Given this list of marker genes BCOR, PDK2, GRIN2A, FAM117A, PAX6, NOL8, APOA5, KAT14, VPS33A, EVC2, IGF2BP3 (NCBI Gene Id 10643), FAM76B, DOHH, LIN28A, AFF2, SFXN2, SAMD12 (NCBI Gene Id 50968), GPRC5C, NTHL1, GTF2A1, RXRB, HIRA, HLX, SRP72, AMD1, PLEKHA6, RRP8, RPS6KA5, PA2G4, TXNDC12, DHX35, MMP23B, FAF1, CEBPB, MARCHF8, RPS11, FHOD1, VGF, ZHX2, GNL1, NDUFAF4, APEX1 (apurinic/apyrimidinic endodeoxyribonuclease 1), BRDT, SPIN2A, FGF11, ZC3H10, CBX6, ALG1, RNF145, FARP1, RPL30, SLC25A51, ESR2, MPV17, MEA1, MCM8, CNPY2, ADNP (NCBI Gene Id 256440), SPNS1, KRTCAP2, CATSPERD, EIF3B, CAMK4, MON1A, GGN, SGTB, SRFBP1, UBXN6, SYBU, EME1, RASGRP2, SNN, CSDE1, METTL13, CEP63, DLX1, ABCA1, ARRDC3, TBL1Y, PLAGL1 (PLAG1 like zinc finger 1), C1orf43, THAP5, RHOBTB3, SPATA2L, LYPD1, PTCH1, PPM1A, ICAM5, CUL5, TOM1L2, ANKHD1-EIF4EBP3, CYP2D6, CACNA1D, ST6GAL1, CHD4, NEUROD6, HMGN2, TBL1X, NDUFA7, CD164, ARMCX6, CGN, FOXF2, PPP1R1B, ADSS2, GABARAP, NR5A1, ZFYVE26, RUNX1T1, BEX1, KCNN4, HOXB4, AK2, BHLHA15, SLC39A11, HYAL2, NRXN1, NUDC, TRIP10, RAB2A, YPEL5, AVP, ACY1, MNT, GPX1, POLH, HSPA4, DYM, B4GALT2, DIAPH1, POGK, FOXRED2, STAT3, NPM1, SUCLG2, ALDH18A1, HPCA, HMOX1, HOXA11, SLC25A33, RCL1, ASPHD1, CHRM1, SLC20A1, ARX, TTLL11, FEN1, SGO1, EWSR1, SERBP1, CACUL1, LMX1A, TUG1, SLC26A2, TCF4, KAT5 (NCBI Gene Id 10524), HEBP2, CAMK2D (calcium/calmodulin dependent protein kinase II delta), ADAMTS3, ARL3, TLL1, DUSP1, ZNF296, SMC3, ADK, DUSP4, ABCB6, TEX12, ARHGAP45, METAP1D (NCBI Gene Id 254042), TMEM132E-DT (TMEM132E divergent transcript), FOXO3, PDP2, NFX1, DOP1A, E2F8, PEPD, ABHD17B, GPC3, EEF1B2, SLC31A2, BEND4, E2F3, NTMT1, BCL9L, GLA, NET1, PRPS1, STX6, TCEAL8, TRMO, SORD, CCAR1, LMNB1, BHLHE40, P3H4, ADAM12, TCEAL1, TIAL1, TBC1D5, STMN1, KLF9, L1CAM, ARHGAP12, BATF3, XPO1, SLC39A7, LTBR, AIFM3, CBARP, MTHFD1, PSMB3, PTMA, TRAPPC8, NEFM, RNF43, LZTS2, RTN4RL2, SEPTIN3 (NCBI Gene Id 55964), LPCAT4, BARHL1, MTAP, HBP1, HSPE1, INO80, HERPUD1 (NCBI Gene Id 9709), EBNA1BP2, DDX4, PIAS4, PRR3, KCMF1, ZFP91, SLC7A5P1, SCFD2, RAB31, ERLIN1, CSK, AGMAT, ZBTB5, ANAPC13, SELENOS, PLCG2, ZCCHC7, ZNRF2, BFAR, CAMKK1, CLN3, KIAA0586, NR0B2, COMMD8, BCKDHA, NXPH1, TSSK3, B3GNT9, ALDOA, IGSF22, ABCC4, UBE2C, FBL, ATXN7L2, TEF, HRH3, TFAP4 (NCBI Gene Id 7023), EIF4G1, SMYD4, ESRP2, TIMM50, ATP6V1H, TRIM3, SHMT2, SUMF1, SEMA3F, CRMP1, HNRNPH3, SLC25A37, SLC7A3, RPS19, TFB2M (NCBI Gene Id 64216), ANXA6, SEMA7A, DERL3, ARMCX2, MGME1, PER1, CHRNA7, WDR77, REV1, SLC17A2, GIGYF2, LHX9 (LIM homeobox 9), PRKCE, MAP7, EMC1, CIPC, AKAP1, TMEM132E, LTV1, STT3B, BCAS3, CNNM1, FAXDC2, ILK, GLS2, ATF1, ZNF711, WEE1, PTGR3, CUTA, ACLY, FPGS, ARMC6, DCAF11, ODC1, PIK3IP1, PWP2, RBM19, PLAG1, ATP1B3, ZC2HC1C, ZBTB8OS, NR1D1, AMER1, RANBP1, ZNF503, HMGA1, ORAI2, XPO5, CEP57, SHOC1, LRP8, MIA2, TGIF2, SLC25A32, U2AF2, PLA2G6, TOP1, SGK1, SLC12A6, ILF3-DT, TMEM258, CLEC18C, NR4A3, ARMCX1, NAPA, SLC7A5, RORC, EIF4B, DNAAF1, WIPI1, DDX18, CPEB4, NKX2-2, DIABLO, TAFA4, SATB2, STC2, ACAN, GLYR1, CHST11, AGO2, DCUN1D4, MEPCE, CNPPD1, DLC1, KDM4C, MXD4, G6PC3, ATP6V1C1, HPS5, SLC33A1, PCDHA10, SPPL3, MPP3, PPP1R3B, KCNH4, WBP2, SSR1, NEUROD1, TSR3, RPS2, GRK6, RPUSD4, FMR1, DTNA, RRAGC, ACAP3, GYG1, KLF11, ATAD3A, DOLK, TSC2, TGFB2, ELK1 (NCBI Gene Id 2002), SEZ6L, MTUS1, CEBPA, SASH3, RETREG2, ENPP6, B3GALT6, IQCG, TNPO2, C15orf39, TNXB (tenascin XB), BMP7, NDUFS1, YBX3, TBX4, JADE2, KANSL1L, RFX4, ALX4 (NCBI Gene Id 64068), DRD1, EFNB1, ATF7IP, RMND1, CFAP57, SUPT16H, TSC1, ATG5, ATP5PB, HNRNPD, BATF2, MAFF, TSPAN4, ONECUT1, POLR1G, SLC43A1, SNCAIP, DSCAM, OGT, VPS13A, HNRNPH2, UBXN10, NOL4L, PNMA8A, UBR4, SPINK5, SDC1, IER5L, PABPC4, NAA25, DENND6A, MRTO4, UTP14A, AP3M1, POLR3C, HPCAL4, ZBTB49, RBBP7, SLC36A1, GPS1, FXR1 (NCBI Gene Id 8087), MFSD5, MEOX2, USP2, KDM6A, ELAVL3, SNRPA, NAT10, ANKRD12, RRAGB, UTP4, NOTCH1, COPZ1, NSD3, POP1, SNX2 (NCBI Gene Id 6643), ADISSP, SEC23IP, FABP3, CELF1, TAGLN2 (NCBI Gene Id 8407), PPAT, IQGAP2, ZNF574 (zinc finger protein 574), FGF14, EN1, ESYT1, AK3, YEATS2, PHC3, RUSC1, TIMM8A, MTCH2, FOXJ3, GNPTG, PABPC1, SCAMP3, HEXA, VLDLR, CLTC, KICS2, USP36, GTF2H1, RTN4R, ATIC, WDR17, GSK3B, PDIA4, SOCS2, ADAM10, COL25A1, CLCN2, NEURL2, TESK2, QTRT2, BDNF, TOM1, ZNF565, LONRF3, KLHDC3, PFDN2, ADCK1, KAT6A (lysine acetyltransferase 6A), AKAP12, ARPC5, ATXN3, PICALM, NPTN, SHMT1, KBTBD2, FCHSD2, REXO2, FOXD3, RPIA, MED28, BCL6, TET2, CEP95, MYO19, TMED10, SMAD2, ETV1 (ETS variant transcription factor 1), HOXC13, TOPORS, SLCO1C1, RAD50, PRDM4, PPP1R3C, EIF3J, RNF115, HSPD1, RBBP4, HOXA1, NUP153 (nucleoporin 153), POLR2H, MICAL2, KCTD15, SPG21, PKN1, PDPR, NOP56, POLR3D, UBR5, GJA1, TMEM108, EN2, CDKN2C, ACACA, THUMPD2, CTBP2, AATF, DNTTIP2, LAP3, ATP6V1A, SNCB, TGFB3, BCL7C, ANGPT2, HOOK2, EPB41, CBX5, INSM1, POLR2L, OBI1, CEP83, ZMYND12, VPS26A, DNAJB9, NRIP3, COPS7A, UBE2B, RNF44, CAMKK2, LDHA, GIT1, ACVR2B, RHEBL1, ABCA2, JADE1, STK31, EYA4, WDR46, HOXB7, ERCC6, VPS50, IRS4, POGLUT1 (protein O-glucosyltransferase 1), SLC4A11, EEF1E1, CCER1, IPO7, SLC38A2, SLC1A7, RSPRY1, UTP18, NUDT11, HSPA9, STMN4, RAD9A, AEN, GK, PSME3, REEP3, C9orf85, MAT2A, MTFP1, RABGAP1, TLE4, SYT6, SLCO5A1, PBRM1, VWA2, CAMKV, BOK, EPC1, BMP2, WASHC4, ADPRHL1, ZNHIT6, PAICS, TAC1, SYNRG, GNAS, SLC12A5, RBBP6, AVPI1, IGF2BP1, HSDL1, XRN2, CREBRF, PRR7, UBE3D, MACROD1, SCYL1, AMPD2 (adenosine monophosphate deaminase 2), SLC17A9, PSEN2, CLUH, MAEL, CTSA, DAZL, NIT1, RARG, CGREF1, POLR3A, SLC6A15, COMMD3, SLC26A10P, RPL13A, PPARGC1A, PTGES3, RRS1, LAMP1, FLT3, MMP23A, TAOK2, TCEAL3, PRMT1 (NCBI Gene Id 3276), IRF9, CEBPA-DT, MCM2, ZBTB11, NCL, OGDHL, HHEX, MID1IP1, HOXA4, BHLHE41, CELSR3, HSP90B1, FAM13B, JOSD1, PPRC1 (PPARG related coactivator 1), EXOSC5, MRPL40, LRFN4, AFF4, GMFB, NTN3, NMNAT2, TIMM9, CNST, LINC02908, EIF3E, NEK6 (NIMA related kinase 6), CDK5R1, FOSL1 (FOS like 1, AP-1 transcription factor subunit), MRM1, ATP7A, ARF6, KLF10, GLB1L, RRP15, PRKCH, KCNE4, TNFRSF21, GTPBP1, ADAMTS17, USP31, POLA1, SIGMAR1, CCDC103, SOCS5, FADS3, HOXA9, VARS2, FLVCR2, HOXC5, GADD45B, ATAD3B, ZCWPW1, LZTFL1, CDK20, CCDC6, USP15, LNPK, ZIC1, IGF2R, ZNF771, BMP6, CMTM8, TRIM46, UNC45B, MORF4L2, GATA5, ARMCX4, OLFM2, ACTMAP, HOXA7, SYT3 (synaptotagmin 3), EIF3A, RNF128, ESRRA, DYRK1B, ATP5MC1, SYNCRIP, BLOC1S1, UBE4B, BMP4, SLC9A5 (NCBI Gene Id 6553), RPA1, BEX3, STEEP1, PFKFB3, SLC49A4, UVRAG, DNAAF6, NOL6, IPO4, FXYD6, FBXO33, WWP2, ZZZ3, IKZF3, RASD2, H2AZ1, SLC35A5, RBM3 (NCBI Gene Id 5935), LIG3, MINK1, SC5D, GET4, IGF1R, TIMM10, TUBA4B, PPP1R9B, PPP2R2B, UBIAD1, RTN4, C21orf91, CEACAM5, BCL9, DLX2, TMEM86A (NCBI Gene Id 144110), C2CD4A, DDX3X (DEAD-box helicase 3 X-linked), LONP1, TADA1, PDCD6IP, ZBTB40, TBC1D15 (TBC1 domain family member 15), PES1, BEX2, VPS16, ZMYM6, RAB24, RGL1, RUNX2, RPS28, VPS37B (VPS37B subunit of ESCRT-I), IPO13, DNAJB5 (NCBI Gene Id 25822), C1QBP, EIF4A1, TCOF1, TSR2, SLC24A4, BAX, POLR3E, IFRD1, EPB41L4B, SNX5, TXLNG, ADGRB2, RAB30 (RAB30, member RAS oncogene family), UQCC2, SIRT1, ASS1, AKAP10, ANKHD1, ENO3, PRELID1, LEF1, TUBA4A, HNRNPM, NUP62CL, TRPM7, ELOVL5, RALYL, SNTB2, ARHGAP17, MCOLN1, SLC38A7, GAR1, ERF, DEPDC7, RELB, HNRNPDL, RCOR2, TPM2, SORL1, RAMP2 (receptor activity modifying protein 2), DCTPP1, SNX16, MDN1, TOGARAM1, GATA4 (GATA binding protein 4), ZBTB10, PUS1, PHF20L1, DUSP7, TCEAL7, FGF19, MBNL1, MICOS13, NPTX1, POU3F2, AGRP (agouti related neuropeptide), PITX3, GET3, IFRD2, NID1, HSP90AB1, ILF3, MIEN1 (NCBI Gene Id 84299), CFL1, FGF6, HAPSTR1, JAKMIP1, GEMIN4, HNRNPF, PLA2G4A, MAPKAPK3, CLIP2, ARHGAP44 (Rho GTPase activating protein 44), URI1, ARRDC4, RNF146, EFTUD2, LYAR, KCNK5, PSME3IP1, SNX8, DCTN4 (NCBI Gene Id 51164), PPARGC1B, CAD, MAX, ARMCX3, DVL2, PHF20, CITED2, BRD2, MYB, OSGEP, FKBP5, FRMD3, CCDC126, DCAF13 (DDB1 and CUL4 associated factor 13), PTGES2, PRKCG, HOXC11, PRRC2C, RHBDD3, CANX, NAA50, PPCS, ATOSB, CDC14A, ANKRD17, SCRT2, HOXC12, TAF6L, TCERG1, AP3D1, RAB3IL1, ATP6V0B, USP34, ASPSCR1, DNMT3A, PATZ1, H3-3A, TMEM59L, ARMT1, OSR1, DZIP1, HS3ST3A1, PIGW, NFATC3, AMMECR1L, HHIP, TRIM37, FKBP10, NCOA6, UTY, TDRD1, CA14, UBA1, DRC3, HNRNPA3, BMP2K, ZNF318, GPM6B, IL15RA, NR6A1, OPRD1, HIF1A, KLHL28, MFHAS1, ZNF593 (zinc finger protein 593), DCHS1, HPS3, GAPDH, MXD3, RFX5, ALDH6A1, GNA13, LMLN, SAE1, CARMIL3, ARHGAP20, CNPY3, NRAS, CCNYL1, ANKRD13B, DDX5, PFN1, ATF4, TRMT2A, MYCL, OSER1, SLC38A5, HSPBAP1, RPL22, KMT2A, ZNF800, COL2A1, C14orf132, PCED1A, TSKU, CCDC191, RBM15B, AMDHD2, TFRC, ATL2, FKBP11 (NCBI Gene Id 51303), SMG1, DPAGT1, TRIB1, KDM3A, UBXN1, RAPGEF6, MRPL27, RLF, CPT1A, GCSH, SOX12, PDIA2, GADD45G, RPL19, SET, ALDH3B1, ADCY3, EGLN2, ATOH8, KCNAB1, DIP2B, FXYD2, C2CD2L, ADAMTS19, HNRNPA1, RIDA, PANK3, HOXA3, QTRT1, CTSF (cathepsin F), IL1RAPL1, CDKL5, B3GALT2, TRMT6, HOXB5, GNB2, HSD11B1L, HOXD10, AP1S2, EIF4E, BCL11B, SUGP2, STXBP2, JPH1, GPD1, FBXL19, LRRC59, HSPH1, RSPO2, CNOT4, FBXL19-AS1 (FBXL19 antisense RNA 1), YBX2, PROK2, YBX1, CTIF, TLE3, GUCY1A2, TMEM47, TMUB1, ARL2 (NCBI Gene Id 402), KCNQ5, NLN, PLBD1 (phospholipase B domain containing 1), MICU1, MANF, PFDN6, SEC11C, PRPS2, CIART, NKX2-3, here is a description of the gene set: Human Gene Set: CACGTG_MYC_Q2 species: Homo sapiens from publication Xie X, Lu J, Kulbokas EJ, Golub TR, Mootha V, Lindblad-Toh K, Lander ES, Kellis M (PMID 15735639) Comprehensive identification of all functional elements encoded in the human genome is a fundamental need in biomedical research. Here, we present a comparative analysis of the human, mouse, rat and dog genomes to create a systematic catalogue of common regulatory motifs in promoters and 3' untranslated regions (3' UTRs). The promoter analysis yields 174 candidate motifs, including most previously known transcription-factor binding sites and 105 new motifs. The 3'-UTR analysis yields 106 motifs likely to be involved in post-transcriptional regulation. Nearly one-half are associated with microRNAs (miRNAs), leading to the discovery of many new miRNA genes and their likely target genes. Our results suggest that previous estimates of the number of human miRNA genes were low, and that miRNAs regulate at least 20% of human genes. The overall results provide a systematic view of gene regulation in the human, which will be refined as additional mammalian genomes become available. Genes having at least one occurrence of the highly conserved motif M2 CACGTG in the regions spanning 4 kb centered on their transcription starting sites. This matches the MYC transcription factor binding site V$MYC_Q2 (v7.4 TRANSFAC).